The following is a description of a gene set: Although Bcr-Abl kinase inhibitors have proven effective in the treatment of chronic myeloid leukemia (CML), they generally fail to eradicate Bcr-Abl(+) leukemia cells. To identify genes whose inhibition sensitizes Bcr-Abl(+) leukemias to killing by Bcr-Abl inhibitors, we performed an RNAi-based synthetic lethal screen with imatinib mesylate in CML cells. This screen identified numerous components of a Wnt/Ca(2+)/NFAT signaling pathway. Antagonism of this pathway led to impaired NFAT activity, decreased cytokine production, and enhanced sensitivity to Bcr-Abl inhibition. Furthermore, NFAT inhibition with cyclosporin A facilitated leukemia cell elimination by the Bcr-Abl inhibitor dasatinib and markedly improved survival in a mouse model of Bcr-Abl(+) acute lymphoblastic leukemia (ALL). Targeting this pathway in combination with Bcr-Abl inhibition could improve treatment of Bcr-Abl(+) leukemias. Genes identified as synthetic lethal with imatinib in RNAi screen in K562 cells (CML, chronic myelogenous leukemia). Human Gene Set: GREGORY_SYNTHETIC_LETHAL_WITH_IMATINIB species: Homo sapiens from publication Gregory MA, Phang TL, Neviani P, Alvarez-Calderon F, Eide CA, O'Hare T, Zaberezhnyy V, Williams RT, Druker BJ, Perrotti D, Degregori J (PMID 20609354), and this is the list of marker genes: TFAP2B, LRRC37A3, ERMP1, SPTB, PGAP2, ITGB1, ATP6V0E1, LIPE, PPP1R2, CAPN6, CXCR4, SP110, SCAF11, CALM1, CEACAM1, H3C7, DBF4, SMARCA1, PRKCQ, SNTA1, SNX10, CELF2, LDLRAD4, SEPTIN6, PDE4DIP, RPL5, ALG10B, RO60, TNFRSF9, MGAT2, PDLIM5, PYROXD1, EPB42, EHF, INTS6L, EGR3, TPM1, API5, RARA, RPL21, CLTA, GPC5, OR2F1 (NCBI Gene Id 26211), FCN3, UCP2, MBD4, TLE1, CYP2B6, DDAH1, SRI, ZP3, IFI16, TAS2R14, GLT8D1, CSHL1, ATP7A, TBCCD1, PLOD2, CAMK2B, GGCX, FKBP11, SP100 (NCBI Gene Id 6672), PGLS, CA5A, CD93, SAT1, CADM4, IL27RA, CLDN3, SETMAR, KAT6A, TRIP11, RPL36A, ATF5, GBP4, CTDSPL, ABCB6, CLTC, CLEC2D, CCL23, CACNA2D2, CTSB, IL4, GAPDH, HLA-DRB5, UBE3A, CUX1, SYT11, ATP2C2, CRYBB2, RPL35, S1PR2, NUDT3, UBA6, GLIPR1, NKRF, ZNF473, COL3A1, SEL1L, PLEKHM1, CRCP (CGRP receptor component), TMEFF1, SORBS1, SKP1, CXCR3, THAP1, RAP1A, CA2, MORC3 (NCBI Gene Id 23515), BAD, KCNJ13, CNR1, UTP14A, ACSL1, ANK3, AZGP1, ZNF140, SV2B, AKR7A2, ITCH, FZD8, CARS1, NRG2, EDF1, CAPRIN1, CST4, RTP4, CLPX (NCBI Gene Id 10845), NCOA3, IRF7, ADAM22, ALDOC, SESTD1, MAML1, HIF3A, SLC50A1, FLT3LG, TJP1, UGT1A7, TRIM24, GTF2H5, HLA-DRA, CPSF1, DLAT, LAPTM4B (NCBI Gene Id 55353)